Given this list of marker genes PMS1, KRAS, PMS2, CHEK2, PIK3CA, MSH6, TP53, PORCN, TGFBR2, NLRP1, CDKN2A, MLH1, EPCAM, CAT (NCBI Gene Id 847), MDM2, RSPO1, MSH2, here is a description of the gene set: species: Homo sapiens Human Gene Set: HP_NEOPLASM_OF_THE_LARYNX Neoplasm of the larynx